Given this list of marker genes D17H6S56E-5, E2f3, Cdca3, Ccna2, Myb, Tyms, Ube2t, Skp2, Pclaf, Plk1, Hmgb2, Ercc6l (NCBI Gene Id 260357), Tal2, Gp1ba, Iqgap3, Psors1c2, Nasp, Bub1b, Aurka, Ccnf, Ube2c, Rprd1b, Kif20a, Fignl1, Cbx2, Kif2c (kinesin family member 2C), Cenpf, H4c6 (H4 clustered histone 6), Tacc3, Ncapg2, Prim1, F13a1, Rad51, Fam111a, Prl2b1, Melk, Ncapg, Shcbp1, Usp1, Cenph, Vmn1r58, Gas5, Nuf2, Racgap1 (Rac GTPase-activating protein 1), Top2a, Cenpk, Nr1d1, Brca1, Pbk, Erdr1, Srsf7, Ncaph, Asf1b, Med1, Depdc1a (NCBI Gene Id 76131), Ncapd2, H2ac7, Tpx2, H4c9, Cdca5, Bub1, Cdc7, Smc2, Ccnb1, Taf1d, Tyms-ps, Hmmr, Rad51ap1, Ccne1, Dna2, Fbxo45, Mcm3, Nup50, H4c1, Ezh2, Psip1, Mapk8, Snord22, Rpl3, Cdc20, Spc25, Rbbp8, Chaf1b, Rbl1, Lmnb1, H4c2, Tk1, Dck, Fen1, Rpl12, Nusap1, Incenp, Kif11, Cenpq, Hjurp, 2610042L04Rik, Spdl1, Dlgap5, Cdc6, H2ax, Rad54l, Prc1, Syce2, Mki67, H4c17, Igf2bp1, Hlx, here is a description of the gene set: Mouse Gene Set: KONG_E2F3_TARGETS Genes up-regulated in MEF cells (embryonic fibroblasts) at 16 hr after serum stimulation and knockdown of E2F3 by RNAi. from publication Kong LJ, Chang JT, Bild AH, Nevins JR (PMID 16909124) studied in species Mus musculus Functions encoded by single genes in lower organisms are often represented by multiple related genes in the mammalian genome. An example is the retinoblastoma and E2F families of proteins that regulate transcription during the cell cycle. Analysis of gene function using germline mutations is often confounded by overlapping function resulting in compensation. Indeed, in cells deleted of the E2F1 or E2F3 genes, there is an increase in the expression of the other family member. To avoid complications of compensatory effects, we have used small-interfering RNAs that target individual E2F proteins to generate a temporary loss of E2F function. We find that both E2F1 and E2F3 are required for cells to enter the S phase from a quiescent state, whereas only E2F3 is necessary for the S phase in growing cells. We also find that the acute loss of E2F3 activity affects the expression of genes encoding DNA replication and mitotic activities, whereas loss of E2F1 affects a limited number of genes that are distinct from those regulated by E2F3. We conclude that the long-term loss of E2F activity does lead to compensation by other family members and that the analysis of acute loss of function reveals specific and distinct roles for these proteins.